Given this list of marker genes ARHGAP26, COL5A1, RAI14, MFAP4, SPARC, CREB3L3, XAB2, RND1, MAPK6, PXMP4, BIRC3, CNPY2, CST7, SASH3, BCL10, MSMO1, CERS4, CCL19, CLEC4A, CIB1, EDN2, TFE3, UCP2, DOCK8, SSTR3, RGS10, DOK1, ARSG, ANAPC1, MANBAL, THY1, TMEM167B, PTPN18, DBNL, PPP1R17, SOX2 (SRY-box transcription factor 2), PSME1, HLA-C, CYP2B6, DHRS7, ADORA2B, SEC23B, NEDD9, TLE3, PTPN6, MAN2B1, AOAH, GUCA1A, LY86, CTSW, ZNF282, PLA2G4E, PIP4K2A, COL6A1, CTSV (cathepsin V), SREBF2, SLC30A6, NMRAL1, ARAP1, ST3GAL4, PAQR7, GPR18, PTK2B, JDP2, NKG7, CHGA, RNASEH2A, HSD3B1, SLC35F2, MBOAT7, ELOVL3, ADAMTS15, PTPRCAP, SLC9B2, PPT1, GTPBP6 (GTP binding protein 6 (putative)), PNPLA5, SH3BP2, PREX1, C3AR1, ALG5, CYBC1, CYTH4, CALHM6 (NCBI Gene Id 441168), PLXNC1, GADD45GIP1, STAP2, UBXN8, FAAH, MFAP2, VSIR, PSME2 (NCBI Gene Id 5721), CCDC137, TEDC1, GALNT6, CMTM7, PAPPA, BRMS1, CSK, LPCAT2, SDF2L1, TNFRSF9, SPATA13, UPB1, BAX, FARP1, DCAKD, SIRPA, CHSY1, CNOT9, LPCAT3, DUSP2 (NCBI Gene Id 1844), ELOVL6 (ELOVL fatty acid elongase 6), MEAF6, CTSC, MAP4K1 (mitogen-activated protein kinase kinase kinase kinase 1), RBCK1, WAS, DOCK5, TMED3, INPP5D, COL1A1, LY9 (lymphocyte antigen 9), CASP8, TTC7A, LY6E, INHBB, DCT, DEF6, HACD2, PXDC1 (NCBI Gene Id 221749), PCTP, ADAM12, ITM2C, STC1, VHL, SEMA4C, TMEM150C, LPXN, LIMA1, CES4A, NUDT17, SPN, COTL1, BET1L, P2RY6, ACSBG1, SLC38A1, FSCN1, KIF11, RCN1, RARRES1 (NCBI Gene Id 5918), GIPC2, RAB5C (RAB5C, member RAS oncogene family), ARHGEF2, P3H1, ARHGEF1, SLC45A3, MTHFS, RPS11, NECAP2 (NCBI Gene Id 55707), ELN, GPR176, RNASE1, SERPINH1, APOE, CKLF, TRAPPC6A, TAPBP, TRMT1, IFI30, CATSPERG, LPIN2, TNFAIP3 (NCBI Gene Id 7128), MED11, QSOX1, LIF, PDZK1, ACSL5, SLC11A2, FAR2, OLFML3, TPCN2, CORO1B, RASA3, CERS5, SEMA4A, B4GALNT1, CPXM1, HSD17B2, RAB43, GMDS, GPAA1 (NCBI Gene Id 8733), RAB4B, DKK3, ESS2, DOCK2, CSF3, SRD5A3, ALOX5, here is a description of the gene set: Genes up-regulated in macrophages: control versus colorectal adenocarcinoma conditioned. Human Gene Set: GSE18804_SPLEEN_MACROPHAGE_VS_COLON_TUMORAL_MACROPHAGE_UP Active immunotherapy is a promising strategy for anti-angiogenic cancer therapy. Recently, we have reported that a vaccine using human umbilical vein endothelial cells (HUVECs) induced specific anti-endothelial immune responses in the most of immunized patients, and resulted in tumor regression in some patients with recurrent malignant brain tumors, whereas not in colorectal cancer patients. In this study, we hypothesized that non-hypoxic perivascular tumor associated macrophages (TAMs) in colorectal cancer, but not in glioblastoma, might negatively alter the therapeutic efficacy of anti-angiogenic active immunotherapy. To test this hypothesis, we examined global gene expression profiles of non-hypoxic macrophages stimulated in vitro by soluble factors released from tumor cells of human glioblastoma U-87MG (‘brain TAMs’) or colorectal adenocarcinoma HT-29 (‘colon TAMs’). species: Homo sapiens